The following is a description of a gene set: The process in which a chondroblast acquires specialized structural and/or functional features of a chondrocyte that will contribute to the development of a bone. A chondrocyte is a polymorphic cell that forms cartilage. species: Mus musculus Mouse Gene Set: GOBP_CHONDROCYTE_DIFFERENTIATION_INVOLVED_IN_ENDOCHONDRAL_BONE_MORPHOGENESIS, and this is the list of marker genes: Sox9, Poc1a, Trip11, Matn1, Tgfbr2, Col27a1, Serpinh1, Rarg (NCBI Gene Id 19411), Nppc, Ihh, Ext1, Atf2, Smpd3, Cst5, Ift80, Scube2, Axin2